The following is a description of a gene set: species: Homo sapiens Secondary microcephaly Head circumference which falls below 2 standard deviations below the mean for age and gender because of insufficient head growth after birth. Human Gene Set: HP_SECONDARY_MICROCEPHALY, and this is the list of marker genes: EIF2B1, EXOSC8, MPC1, NACC1, WDR73, RUSC2, TSEN2, TBC1D20, RNASEH2A, HNRNPH2, CDC42, WWOX, FTO, PCDH12, NTRK2, PAFAH1B1, SLC25A22, OCA2, CCDC88A, SLC25A12, PNKP, TSEN54, ERCC8, PLEKHG2, EXOSC9, PLAA, RNASEH2C, PNPO, UBE3A, CACNA1B, TSEN34, VPS53, PYCR2, ATP6V1E1, GRIN2A, DYRK1A, MGAT2, AMPD2, CNP, SLC9A6, AGTPBP1, NTNG1, CDC45 (cell division cycle 45), DEGS1, ASNS, NAPB, TAF2, CDKL5, DPM1, MED17, DIAPH1, WARS1, MDH1, COG1, POMK, TOMM7, HTRA2, GLYCTK, NDUFA11, TCF4, JAM3, SLC39A14, YRDC, TSEN15, C2orf69, ARNT2, ATP5PO, FRA10AC1, VRK1, ITPR1, HNRNPR, CLPB, CC2D1A, FOXG1, NDUFS1, COG6, LGI3, VARS1, CRLS1, ATP1A2, BCKDK, EXOSC3, PRORP, RAB3GAP2, PUS3, SATB1, HIKESHI, ALG12, NAT8L, CASK, UBA5, RNU4-2, SLC12A5, MFSD2A, ACTG1, LAMB2, SPTAN1, BRAT1, SLC1A4, ATP9A, GABRA5, TREX1, PTRH2, PLPBP, ARFGEF2, WDR37, GCSH, PSAT1, SMPD4, IQSEC2, SDHD, TMEM165, RAP1B, SLC25A46, ZSWIM6, MBD5, NGLY1, SLC2A1, TRAPPC6B, GABRB2, CHMP1A, ATP6V1A, CERT1, COG2, EMC1, COG8, KIF5C, RAB18, GRIA2, ERCC6, VPS50, SMC1A, COQ9, MICOS13, ALG1, DCX, GLS, FGF12, TOE1, TRAPPC2L, UFC1, ATP6V0A2, DOLK, EP300, PPP1R12A, RNF113A, FAR1, IARS1, CTNNA2, CARS2, PARS2, EEF1A2, DHFR, ADAM22, GOLGA2, ZNHIT3 (zinc finger HIT-type containing 3), TBC1D24, DNM1, MFF, QARS1, UBTF, VPS11, STAMBP, GPT2 (NCBI Gene Id 84706), TRAPPC9, GON7, EFTUD2, ATP10A, PCLO, TRIO, TBCD, PMPCB, SMC3, SLC18A2, SCN1A, SNRPN, PIGA, SCN8A, FOXRED1, MECP2, NEXMIF, PPT1, ACO2, TUBGCP2, CLTC, DPM2, PUF60, EXOC2, SEPSECS, ALG9, RARS2, CREBBP, COG7, GOT2, HSPD1, ACBD5, ZEB2, GABBR2, SNAP29, EXTL3, CLP1, TRAPPC12